The following is a description of a gene set: Human Gene Set: GOBP_MIDGUT_DEVELOPMENT species: Homo sapiens The process whose specific outcome is the progression of the midgut over time, from its formation to the mature structure. The midgut is the middle part of the alimentary canal from the stomach, or entrance of the bile duct, to, or including, the large intestine., and this is the list of marker genes: CPS1, FOXF1, EDNRB (endothelin receptor type B), FOXL1, RET, ASS1, ALDH1A2, HMGCS2, WNT5A, OTC, SMO